The following is a description of a gene set: Human Gene Set: PU1_Q6 species: Homo sapiens Genes having at least one occurrence of the motif WGAGGAAG in the regions spanning 4 kb centered on their transcription starting sites. This matches the SPI1 transcription factor binding site V$PU1_Q6 (v7.4 TRANSFAC)., and this is the list of marker genes: STAT6, TCTA, PKN1, FKRP, GIMAP4, ARID1A, RREB1, SLC9A1, PRADC1, RHOA, ACVRL1, FUT8, SEPTIN1, ADAMTS1, ADAM15, CX3CL1, PATZ1 (NCBI Gene Id 23598), ELN (NCBI Gene Id 2006), PTPRCAP, SSTR5-AS1, NCF2, RAB5C, SSBP4, DPP8, ZNF384, LRRFIP1, SLC16A13, ESRP2, VAV1, NR1H3 (nuclear receptor subfamily 1 group H member 3), CTSG, MRPL49, FCGR1A, PUS7L, MR1, CSF1, HSALR1 (HSP90AB1 associated lncRNA 1), SOST, TFAP2C, TNFSF13, CTSA (cathepsin A), LAMA3, PAX2, IL18, CYTOR, TRPM3, KLK13, PIK3CG, NAV1, SESN2, CCT7, TWIST1, NDN, PBX1, HNRNPUL1, GRIK2, SNAI1, UBE2D3, LECT2, ONECUT1 (one cut homeobox 1), FCRLA, MXD4, PIEZO1, APOBR, FOXA1, PDLIM2, PPP1R10, TFB2M, ATP5PD, ARHGEF4, SP6, EVI2B, ACTR2, MED15, ABI3, NEURL2, CBX8, LCP2 (NCBI Gene Id 3937), PCDHGA5, DGKZ, IRAK4, ERF, PTBP3, CLUH, DALRD3, URB1-AS1, TBXAS1, HNRNPA3, SPATA6, ABI1, KMT2E, PPP1R14C, CEBPG, PLCB2, ATP5MC1, MSH5, PACC1, DNAI1, ASTN1, GIT2, TLR4, USP46, DERL3, CCDC88B, CD101, RORA, MTPN, SHISA7, RAB8B, NR2C2, ILRUN, CSAD, PHOX2B, KCNAB1, RPL17, SESN3, MRPL17 (NCBI Gene Id 64996), GLT8D2, SEC24B, METTL8, SLC43A2 (NCBI Gene Id 124935), KDM2A, CLIC1, PABPC1, KCNQ1, LYN, EIF4EBP1, TBC1D10C, CHRM4, BIRC3, MAPK3, ADGRG3, CDKN2A, TCN2, MPO, FYN, HOXB8, TREML4, WIPI2, FBXL20, SSTR5, FAM219A, SIRPA, BEND6, CNOT6L, TACR1, CCDC136, MKX, SCAF11, MOB3C, GLYR1 (glyoxylate reductase 1 homolog), ADAM11, RCBTB1, RINL, POU2F1, TMEM229B, PPP1CA, ELOVL5, JAKMIP2, CREB5, IRF2BPL, SLC39A5, RERG, FAU, SCRT2, GPN2, NHERF1, PCSK5, RNF111, H1-10, ZIC2, STRN4, TNFSF11, KIFC3, FBXW4, STAP1, CALHM2, MARCHF1 (membrane associated ring-CH-type finger 1), NAV2, LTB4R, CKB, ANKRD20A19P, LAIR1, SEMA6B, FGF12 (fibroblast growth factor 12), FAM110A, NDUFAF3, MRPS18B, ELMO1, ADNP, NCK1, SHISA6 (shisa family member 6), EIF3E, PTPN22, FAM81A, ICAM2, ESAM, IRF8 (NCBI Gene Id 3394), ADORA3, PAK1IP1, SLC27A3, LIMD1, POLD4, CD37, PTK7, PCDH9, GNGT2, NCKAP1L (NCK associated protein 1 like), CLNK, NINJ2, ETV1, JARID2, ARHGAP8, NFKB2, SLC9B2, CEBPE, LTA, VDAC2, PSMD9, GATA3, DCAF17, KMT2D, ITPRIPL1, ZNFX1, GRID2, ARHGAP30, HOXC4, RAB20, SIK3 (NCBI Gene Id 80236), C1orf162, CNST, ANKRD28, PTMS, ADORA1, ATP2A3, DENND2B, DOP1A